Given this list of marker genes ITPR1, NSD1, TARDBP, C9orf72, PSEN1, CHCHD10, TBK1, CACNA1A, MAPT, HNRNPA1, VCP (NCBI Gene Id 94731), SRY, TREM2, CYLD, HNRNPA2B1, FMR1, MAP1B, PNKP, CHMP2B, SQSTM1, APC2, GRN, FUS, TMEM106B, here is a description of the gene set: Dyscalculia studied in species Homo sapiens Human Gene Set: HP_DYSCALCULIA A specific learning disability involving mathematics and arithmetic.